Given this list of marker genes REEP5, UCK2, NEU1, TNFRSF11B, COL8A1, TPBG, CASP4, CAT (catalase), TMEM59, TNFRSF1A, ARL4C, MXRA7, ARPC5, SEC61B, NPDC1, PLAU, EHD1, BAG3, ACADVL, CLU, GLIPR1, VOPP1, HEXB, WDR45, MMP2, ELK3, IRAK1, DPYSL3, CD151, ELL2, CHPF2, TPGS2, SEC24D, TMEM43, OSBPL3, LY6E, STEAP1, MYO1B, IGFBP3 (NCBI Gene Id 3486), PDGFRA, TFE3, IDH1, ECM1, RAB1A, MFSD1, CHMP2B, SNX7, ATP10D, KLF2, GRAMD2B, FGF2, NECAP2, SPHK1, PTEN, APLP2, ARF4, NNMT, DOK4, VKORC1, IDS, AVPI1, RAB31, MCFD2, GRN, CAP1, CAST, ANXA1, NRG1, COPB2, YKT6, P4HA1, TPST2, BACE1, UAP1, GSTO1, SKAP2, CLTA, IGFBP6, SQOR, TMEM184B, CCND1, TM4SF1, SERP1, FEZ1, IQGAP1, RAB11FIP5, GALNT1, HEBP2, GMDS, GNG12, NUCB1, LXN, RRAGC, PTPN13, PGRMC1, SMAD7, SMAD3, NSMAF, DCBLD2, PRR13, COPZ2, ELOVL5, S100A10, CAV2, WLS (NCBI Gene Id 79971), SLC39A6, SLC25A32, SMTN, GORASP2, IL13RA1 (NCBI Gene Id 3597), CALU, ANXA2, PPIC, CEMIP, XYLT1, JAK1, MAN2A1, PTGES, VAMP3, LPP, THBS2, PLPP3, NPTN, ANXA7, GLRX, FSTL1, LOXL2, NT5E, MYH9, NRP1, EOGT (NCBI Gene Id 79580), SCP2, S100A6, KDELR3, PRAF2, LEPROT, CCN2, IFT20, ACSL4, AP1S1, ITGA5, TGFB1I1, ALG5, ATP6AP1, FKBP11, WDR1, P4HB, ADAMTS2, PEA15 (NCBI Gene Id 8682), SRPX2, PKD2, SEC24A (NCBI Gene Id 10802), PITPNA, CREB3L1, VAT1, RAB32, LAMA4, LAMP2, YIPF5, LOXL1, OSMR, CLIC1, LRRC59, SLC10A3, CLTB, CLIC4, TAPBP, COL5A1, MYLK (NCBI Gene Id 50483), CD248, CSTB, PTX3, RHOA, OSTM1, GABARAPL1, SPAG9, ACTR2, SWAP70, FNDC3B, MCUB, NQO2, PRKCA, CCPG1, CREB3L2, PARVA, ID3, FXYD5, PRKD1, TSPAN4, MTMR6, DUSP14, RAB21, QSOX1, TUSC3, SCPEP1, LGALS8, LGALS3BP, PAPSS2, NDEL1, P3H3, RRAS, FHL2, ARF1, C1GALT1C1, P3H1, RAC1 (Rac family small GTPase 1), FKBP14, RAB23, ITGBL1, LPAR1, GNS, GULP1, ZYX, EFEMP2, STX12, AP2S1, CST3, ANXA5, CORO1B, ARHGDIA, RHOC, UBE2A, AP2M1, GRSF1, TGFBR2, ATOX1, INHBA, BDNF, SERPINE2, ABHD5, FZD1, RCN3, ACTN4, PAPSS1 (NCBI Gene Id 9061), MFGE8, CLIP1, EXT1, IL10RB, GFPT1, TPM4, BMP1, SFXN3, NDST1, SMURF2, SLC25A1 (NCBI Gene Id 6576), CDR2, LAMP1, ASAP1, CAV1, ADAM10, PLAUR, PDXK, AXL, COL6A2, VEGFC, CAPZB, STAT6, TNFRSF12A, MAN2B2, NUCB2, ACTN1, PLEKHB2, TGFBI, C1S, FAP, ADAM9, THBS1, BCAP31, TXNDC5, ATP6V0D1, ATG5, GNAI2, TGFB1, EMP1, CBR1, FZD2, KLF6, RAI14, FBN1, NANS, ARPC3, PDLIM2, CTTN, CMTM6, EDIL3, ANO10, EPHX1, CTSB, SEMA3C, EBP, SLC39A14, PRPS2, IGFBP7, MSN, RAB5C, TIMP2, CAVIN1, LMAN1, FBLN5, LRP1, UGDH, STX7, HSPA13, ELF4, TMOD3, SH3BGRL3, SIDT2, ITGAV, PXDC1, PRDX4, CAPG, TPST1, YIPF6, S100A13, PLAT, HTRA1, MBNL1, SCARA3, TSPO, TMED3, DYNLT3, WIPI1, PDGFRB (NCBI Gene Id 5159), RABAC1, LIMA1, ENDOD1, TMEM45A, ERP29, QPCT, COL1A1, PLOD1, COQ10B (NCBI Gene Id 80219), TPP1, DRAM1, TMED5, SNAP23, RHBDF1, EGFR, TRAM2, RAP1B, B4GALT1, FTSJ1, PLSCR3, CD81, EFEMP1, FSTL3, CNN2, PAM, SLC35A2, CCN1, TMEM165, ARPC1B, PSMD9, NGF, VCAN, GJA1, TLN1, MRC2, SNX2, RFTN1, ATP10A, VDR, DOK1, DAB2, TMEM9B, ELF3 (E74 like ETS transcription factor 3), TWIST1 (NCBI Gene Id 7967), RRBP1, PCOLCE, TIMP1, SLC33A1, NTAN1, ELOVL1, ATP6AP2, ATP6V0E1, COL5A2, MCTS1, FKBP10, TVP23B, TAGLN2, AMMECR1, COL6A1, ENG, STK39, PLS3, GAS6, PDLIM5, FN1, LOX, GPR176, CUL4B, TFPI2, PDCD6, PDGFC, ATG3, NQO1, MMP14, COL8A2, PRRX2, EPAS1, LAMC1, GSN, SSH1, LBH, TMEM50A, ARSJ, DUSP1, here is a description of the gene set: Genes commonly down-regulated in human alveolar rhabdomyosarcoma (ARMS) and its mouse model overexpressing PAX3-FOXO1 fusion. species: Homo sapiens from publication Ren YX, Finckenstein FG, Abdueva DA, Shahbazian V, Chung B, Weinberg KI, Triche TJ, Shimada H, Anderson MJ (PMID 18701482) Alveolar rhabdomyosarcomas (ARMS) are highly malignant soft-tissue sarcomas that arise in children, adolescents, and young adults. Although formation and expression of the PAX-FKHR fusion genes is thought to be the initiating event in this cancer, the role of PAX-FKHR in the neoplastic process remains largely unknown in a progenitor cell that is undefined. We hypothesize that PAX-FKHR determine the ARMS progenitor to the skeletal muscle lineage, which when coupled to the inactivation and/or activation of critical cell signaling pathways leads to the formation of ARMS. Because a number of studies have proposed that mesenchymal stem cells (MSC) are the progenitor for several of the sarcomas, we tested this hypothesis in MSCs. We show that PAX-FKHR induce skeletal myogenesis in MSCs by transactivating MyoD and myogenin. Despite exhibiting enhanced growth in vitro, the PAX-FKHR-expressing populations do not form colonies in soft agar or tumors in mice. Expression of dominant-negative p53, or the SV40 early region, elicits tumor formation in some of the PAX-FKHR-expressing populations. Additional activation of the Ras signaling pathway leads to highly malignant tumor formation for all of the populations. The PAX-FKHR-expressing tumors were shown to have histologic, immunohistochemical, and gene expression profiles similar to human ARMS. Our results show the critical role played by PAX-FKHR in determining the molecular, myogenic, and histologic phenotype of ARMS. More importantly, we identify MSCs as a progenitor that can give rise to ARMS. Human Gene Set: REN_ALVEOLAR_RHABDOMYOSARCOMA_DN